The following is a description of a gene set: mouse primary BMDCs were stimulated with tlr ligands and gene expression changes were profiled on Affymetrix arrays species: Homo sapiens Genes up-regulated in comparison of dendritic cells (DC) stimulated with poly(I:C) (TLR3 agonist) at 0.5 h versus those stimulated at 8 h. from publication Amit I, Garber M, Chevrier N, Leite AP, Donner Y, Eisenhaure T, Guttman M, Grenier JK, Li W, Zuk O, Schubert LA, Birditt B, Shay T, Goren A, Zhang X, Smith Z, Deering R, McDonald RC, Cabili M, Bernstein BE, Rinn JL, Meissner A, Root DE, Hacohen N, Regev A (PMID 19729616) Human Gene Set: GSE17721_0.5H_VS_8H_POLYIC_BMDC_UP, and this is the list of marker genes: ATP2A1, CSN2, NOP58, PUM3, MRPL54, MRPS2, NLK, DGAT1, KDELR2, MKNK2, CCT6A, PCDH8, NRCAM, RTCB, MBP, PITX1, MED22, CDC23, ARMC6, IFRD2, MRPL47, MMP17, TK1, TSSK2, SFXN3, N4BP2L1, EIF3F, NIT1, ADCY2, TMEM51, UFSP2, POLR2F, SLC18A1, FOXM1, SEC16A, TXNL4A, RIN1, ZNF703, OLA1, PADI1, C1orf174, CPSF1, ZMPSTE24, HIC2, CLEC6A, OSBPL2, GDI2, SUPT5H, RALBP1, RP9, IPO4, PDXK, SLC30A5, DUSP6, CETN2, BCAP29, TCEAL9, LIMK1, GLMP, ENPP1, LSM4, IDH3A, JMJD8 (jumonji domain containing 8), PISD, SLC41A3, PRMT7, MRPS15, COPS5, PALD1, AACS, USP20, CLNS1A, CCR2, CUTA, CDKAL1 (NCBI Gene Id 54901), HARS1, GYS1, CTNNA1, TAF10, LCE3B, OGFOD2 (2-oxoglutarate and iron dependent oxygenase domain containing 2), CUEDC2, ARL2, JPH2, TIMM9, PC, GRWD1, MAP3K3, MYL9, PALM, NUCB1, TAFA5, CEP250, TMEM123, RPL13A, MRPL30, RNF123, COA6, ANGEL2, GUSB, NCALD, HEPACAM2 (HEPACAM family member 2), MSLN, DNAJC9, ORMDL2, NAA60, ST6GALNAC6, ACOX1, CAV3, GALK2, ERAL1, PNO1, CERS5, BTBD1, VCP, THOC1, ADH7, LCMT1, TUBA1A, GEMIN6, STMP1, ACTR1B, SHMT1, IMPACT, WDR45, PMVK (phosphomevalonate kinase), COA7, SIPA1, MAP4K4, BUB1, ATRX, EMD, LTBR, UTP11, RPS3, FBF1, SFRP4 (NCBI Gene Id 6424), BRD8, SKI, SPRR2F, CCT2, RGS19, GRK2, PRKAG1, CHST10, RIOK1, NDUFAB1 (NADH:ubiquinone oxidoreductase subunit AB1), ACADVL, NSMF, RFC1, TFEC, RAB31, PRODH, XBP1 (NCBI Gene Id 7494), TUSC2, ACAT1, HOXB2, TRIM41, EBP, MRAS, SLC35A1, SCAND1, EIF4G1, MRPL3, BRD3, PPP1CC, LEPROT, THOC7, STRBP, CCT7, MPV17, IL6ST, HTATIP2, MCM2, PARK7, MDH1, ATP5MC3, NCOR2, PEPD, IER3, NKD1, RNF7, NHP2, VDAC1, APIP, SCEL, MARCO, FTSJ1, GNPNAT1, WASHC2A, SC5D, PSMB2, NME2, RPLP1, ERBB4, C11orf71, SNX15, FCGR2B, ZFP2, SETDB1